The following is a description of a gene set: species: Homo sapiens Neighborhood of FANCG Human Gene Set: MORF_FANCG Neighborhood of FANCG Fanconi anemia, complementation group G in the MORF expression compendium, and this is the list of marker genes: PML, PCGF1, MGAT1, BAHD1, PWP1, DKK4, RASSF1, CRHR2, NUP62, LEPROTL1, NFRKB, SRRT, F7, IMPA1, PIGR, HTR4, KMT2D, CLPX, PIGB, RPRD2, ENTREP3, MKI67, PMF1, POLR2A, TFAP4, SFSWAP, TAF2, DIP2C, ATRX, HNRNPL, PSMD3, DAXX, CHD3, NELFB, OARD1, MT4, CDC25C, PKN2, NKRF, ZNF500, SMC5, PPP5C, PAXIP1, WDR62, AGPAT1, SLC22A24, SLC30A3, MOK, BTD, AP3B1, HSF4, LBP, SH2B1, TMEM11, NUDT3, PITPNM1 (NCBI Gene Id 9600), KLHL18, ACKR2, ERCC2, PVT1, LSM1, PHB1, ARSL, CSNK2A1, GRIP2, TPR (translocated promoter region, nuclear basket protein), LDB1, MTX1, B4GALT3, NFYB, DTNA, GFUS, FRYL, CSTF3, SSTR5, KDM3B (NCBI Gene Id 51780), PPIL2, CLP1, SPEF1, BPHL, GRIK5, PLIN3, PAFAH1B1, PRKCSH, IKBKG, MR1, RBBP8, TMEM94, SLC12A4, CALCOCO1, SIK3, PCBP3, PAX8, ILVBL, PCGF2, ERAL1, MPP2, RPS6KB2, AQP5, GALNT2, EIF5B, IPCEF1, DNA2, RANBP2, FDXR, BMS1, MYO9B, CHD9, ADAMTSL2, CDK13, AMFR, XPO6, ZNF271P, RERE, SLC4A3, CARD10, ZKSCAN3, EML3, MFN2, SLC6A9 (solute carrier family 6 member 9), CCNF, TTI1, GSK3B, SLC2A1, WWOX, ECE2, DDB1, HAUS5, CPSF4, SS18, MC2R, MSX1, DDX11, SLC5A2, BCL2, PKMYT1, DOK1, FANCG, IRF2BP1, JRK, ZNF592, EXTL3, PRKAG1, CRYBA4, ENTREP1, HSPB2, HTR7 (5-hydroxytryptamine receptor 7), NDST1, CNP, RFC1, STK19, CD8B, RPA2, SLC24A1, NUP188, KIFC3, SLC25A11, TCOF1, PARN, IGSF9B, SEC31A, GTF2H3, ADAM15, LSM12, IRF2, MEA1 (NCBI Gene Id 4201), DNAJC7